The following is a description of a gene set: studied in species Homo sapiens Human Gene Set: GOBP_CELLULAR_RESPONSE_TO_ANGIOTENSIN Any process that results in a change in state or activity of a cell (in terms of movement, secretion, enzyme production, gene expression, etc.) as a result of an angiotensin stimulus. Angiotensin is any of three physiologically active peptides (angiotensin II, III, or IV) processed from angiotensinogen., and this is the list of marker genes: SRC, SLC30A10, PRKD1, ACE, CDC6, NFKB1, RAC1, CAV1, MIR145, HSF1, CAMK2A, FAM114A1, RAP1GDS1, ACTN2, NONO, NFE2L2, PRKCD, AGT, MAP3K7, ROCK2, ROCK1, PPP3CA, CA2, PRKCA, DDR2, RELA, INHBA, MAS1, AHCYL1, PTPN1 (protein tyrosine phosphatase non-receptor type 1), AGTR1, NPPA, MIR143, SLC26A6, FAT1, AGTR2, PLA2G2A, CYBA, AGTRAP